Given this list of marker genes PSMA6, PSMC3, PSMA3, PSMA7, UBA52, CDK4, PSMA2, PSMD14, PSMD1, PSMB2, PSMD13, UBB, PSMA1, PSMB6, PSMA5, PSMB1, UBC, PSMB4, PSMD6, PSMC5, PSMD3, PSMD8, SEM1, CCND1, PSMC2, PSMB5, PSMA4, PSMD2, PSMC1, ADRM1, PSMC4, PSMD12, PSMD7, PSMB3, RPS27A, PSMB7, GSK3B, PSMC6, PSMD11 (proteasome 26S subunit, non-ATPase 11), here is a description of the gene set: Ubiquitin-dependent degradation of Cyclin D studied in species Homo sapiens Human Gene Set: REACTOME_UBIQUITIN_DEPENDENT_DEGRADATION_OF_CYCLIN_D